Given this list of marker genes Draxin (dorsal inhibitory axon guidance protein), Nkx6-2, Lhx5, Itgb1, Ctnnb1, Gdf7, Bmpr1a, Erbb4, Olig3, Hoxc10, Foxp2, D16Ertd472e (DNA segment, Chr 16, ERATO Doi 472, expressed), Lhx1, Wnt9b, Id4, Drd2, Szt2, Robo2, Ntrk2, Sema3e, Hprt1, Nin, Dbx1, Samd4b, Nova2, Evx1, Atp2b2, Gsx2, Bmpr1b, Rapgef2, Nkx2-2, Arx, Nkx6-1, Wnt1, Nhlh2, Ephb1, En1, Psen1, Ryk, Fgfr2, Lhx3, Mir17, Gnaq, Atg7, Nkx2-1, Lmx1a, Barhl2, Mycbp2, Pou3f2, Notch1, Lbx1, Tbx20, Herc1, Mtpn, App, Ascl1, Zdhhc16, Skor2, Ighmbp2, Wnt3a, Apbb1, Ndel1, Npy, Grid2, Wnt2, Uncx, Kndc1, Slc25a46, Lonrf2, Mir200a, Smo, Dlx1, Tulp3, Rac1, Mir9-3, Fezf1, Mir19b-1, Neurog2, Brsk2, Gba1, Dicer1, Map2k1, Ulk4, Epha4, Pax6, Mnx1, Sox2, Ldb1, Elavl4, Mir19a, Isl1, Ptk2, Cacna1a, Gdf11, Scyl2, Zhx2, Scyl3, Tsku, Pals1, Gli3, Rora, Atoh1, Zswim6, Smarcc2, Brinp2, Ift172, Ophn1, Dvl3, Tal1, Ulk1, Btg2, Ntf3, Hes5, Gabrb1 (NCBI Gene Id 320243), Sptbn4, Mir9-2, Nrp2, Tox, Ptger3, Nfib, Otp (NCBI Gene Id 18420), Dmrt3, Pafah1b1, Shh, Brinp3, Gbx1, Cdh11, Miat, Plxna4, Cdk5, Neurod1, Mir141, Chrnb2, Bcl6, Taok1, Sfrp2, Faim2, Uqcrq, Tctn1 (NCBI Gene Id 75325), Sall3, Fbxo45, Ttll1, Sfrp1, Prkca, Fezf2, Grcc10 (NCBI Gene Id 80671), Arhgef28, Ephb2, Slit2, B4galt5, En2, Cntn2, Pax3, Zfp335, Csf1r, Kifbp, Lhx6, Bcl11b, Crk, Hoxd10, Prdm8, Dync2h1, Wnt7a, Foxg1, Pten, Rorb, Sox1, Ptf1a, Tfap2a, Phox2b, Fat3, Agbl4 (NCBI Gene Id 78933), Sall1, Arhgap35, Lingo1, Mib1, Lep, Cbln1, Robo1, Dlx5, Sufu, Dkk1, Nr4a2, Phox2a, Pou4f2, Gata2, Mir200c, Mir200b, Prox1, Lhx4, Spock1, Inhba, Pou4f1 (NCBI Gene Id 78006), Ikzf1, Bhlhe22, Dlx2, Zmiz1, Mir9-1, Neurod4, Zeb2, Sox5 (NCBI Gene Id 319649), Lmo4, Spg11 (SPG11, spatacsin vesicle trafficking associated), Tgif2, Abt1, Zc4h2, Chd5 (NCBI Gene Id 75229), Crkl, Hoxa1, Mir18, Ogdh, Dab1, Gbx2, Lhx8, Kcnq2, Dll4, Gigyf2, Epha2, Gdpd5, Sema3a, Atxn2, Hes1, Mir92-1, Drd1, Mir429, Cdon, Fgfr1, Dcx, Ubb, Disc1, Isl2, Dclk2 (doublecortin-like kinase 2), Dclk1, Foxn4, Nrxn1, Wdr47, B2m, Shank3, Vsx2, Tbr1, Nfix, Mir376a, Efna1, D130043K22Rik, Nrp1, Plxna1, Lhx1os, Gli2, Pax7, Brsk1, Pex5, Ttc21b, Eomes, Brinp1, Agtpbp1, Pou3f4, Psap, Tgif1, Nanos1, Cend1 (cell cycle exit and neuronal differentiation 1), Tfap2c, Nr2e1, Tuba1a, Ptch1, Sin3a, Scn1b, Fgf8, Ndnf, Lypd6, Emx1, Adarb1, Plxna3, Lmx1b, Mir20a, Wnt5a, Gba2, Rac3, Nfe2l1, Atp7a, Runx1, Slc4a10, Wnt3, Gsx1, Scyl1, Cln8, Casz1, Unc5d, Csnk1d, Atf5, L1cam, Dcc, Secisbp2, B4galt6, Ttc36 (NCBI Gene Id 192653), Olig2, Dubr, Ephb3, here is a description of the gene set: The process in which a relatively unspecialized cell acquires specialized features of a neuron whose cell body resides in the central nervous system. Mouse Gene Set: GOBP_CENTRAL_NERVOUS_SYSTEM_NEURON_DIFFERENTIATION studied in species Mus musculus